Given this list of marker genes SCNN1B, SCNN1A, CACNA1D, HSD11B2, CYP11B1, AVPR2, CYP17A1, NR3C2, POR, WNK1, SCNN1G, KCNJ5, here is a description of the gene set: studied in species Homo sapiens Decreased circulating renin concentration Human Gene Set: HP_DECREASED_CIRCULATING_RENIN_CONCENTRATION An decreased level of renin in the blood.